The following is a description of a gene set: Any process that decreases the frequency, rate or extent of mesenchymal cell proliferation. A mesenchymal cell is a cell that normally gives rise to other cells that are organized as three-dimensional masses, rather than sheets. species: Mus musculus Mouse Gene Set: GOBP_NEGATIVE_REGULATION_OF_MESENCHYMAL_CELL_PROLIFERATION, and this is the list of marker genes: Ptn, Lmna, Nfib, Phf14, Wnt11, Wnt5a, Ctnnbip1, Isl1, Bmp4